The following is a description of a gene set: species: Mus musculus Mouse Gene Set: MIR_7675_3P Genes predicted to be targets of miRBase v22 microRNA mmu_miR_7675_3p in miRDB v6.0 with MirTarget v4 prediction scores > 80 (high confidence targets). from publication Chen Y, Wang X (PMID 31504780), and this is the list of marker genes: Jakmip2, Vcan, Tent5a, Marcksl1, Kctd12, Scx, Rbm41, Nkiras1, Zfp719, Eps15, Ccp110, Hecw1, P2ry1, Wwtr1, Ell2, Cox6c, Krtap4-22, Tgfbr3, Ddx21, Npas3, Ankrd34b, Tfap2a, Emilin2, Slxl1, Rnpc3, Bcar3, Trim21, Adamtsl1, Prmt8, Ift80, Xpot, Ankrd29, Tm9sf3, Nepro (nucleolus and neural progenitor protein), Nudcd1, Tnfaip8l3, Rapgef4, Pex12, Pik3c3, Tfdp1, Clic5, Elavl4, Bicd1, Tmem60, Prpf40a, Arpp21, Herc1, Gng10, Stt3b, Skint10, Nfkbiz, Trim45, Bicral, Msi2, Zfp273, Ddx39b, Galnt16 (polypeptide N-acetylgalactosaminyltransferase 16), Tshz3 (NCBI Gene Id 338507), Pds5b, Gpr174, Cd48, Exoc5 (exocyst complex component 5), Nos1ap, Terb2, Dennd4a, Hmga2, Otud6b, Crebzf, Pard3, Prkx, Trip12, Nudt11, Pde12, Cnot4, Lrrc58, Chac2 (NCBI Gene Id 68044), Plekhm3, Robo2, Sec22a, Met, Rpusd2, Pfdn4, Socs2, Hnf4g, Retnlb, Pik3r2, Nkapd1, Acox3, B230219D22Rik (RIKEN cDNA B230219D22 gene), Fgd4, Zfp1006, Lmln, Stc1, Adamts5, Nufip2, Xkr6, Pptc7, Tubgcp4, Mier1, Glce, Thbs2, Fign, Trim68, U2surp, Rora, Dbt, Klf6, Zfp799, Ifi202b, Zfand5, Trps1, Slc4a4, Snx27, Pdpk1, Arrdc3, Mturn, Mfsd8, Dll4, Kpna3, Rag1 (recombination activating 1), Peg10, Skil, Rc3h1, Or51e2, Sgo1, Neu3, Pde7a, Rab5b, Slc5a3, Gm15881, Tox, Cnksr2, Ube2d2a, Nmt2, Ssmem1, Mysm1, Usp15 (NCBI Gene Id 70921), Magi2, Ppp1r3g, Chsy3, Zfp831, Kank3, Nadk2, Erbb4, Krtap20-2, Tcaim, Scoc, Gabra2, Teddm1b, Mex3c, Arl5a, Atp11c (NCBI Gene Id 54668), Dld (dihydrolipoamide dehydrogenase), Slc4a10, Ifi214, Osgin2, Ccdc178 (NCBI Gene Id 70950), Utrn, Prpf38b, Slc38a2, Ints8, Lnpk, Matr3, Uri1, Slc8a1, Mdga2, Dusp8, Rpgr, Dctn4, Acap2, Ddx4, Bmpr2, Mtfr1, Tmed5, Pgm2l1, Slco6d1, Hsd11b1, Fam199x, Spen, Adra1a, Sult1b1, Mbnl2, Rap1gds1, Wdr76, Map4k3, Larp4, Nedd4l, Zfp292, Plag1, Smu1, Acvr2b, Zic5, Jpt2, Chic1, Cul4a, Tmem168, Stau2, Pros1